Given this list of marker genes NDUFAB1, MRPL20, TPBG, DGCR6, CPEB1, FAM53A, CCER1, GUCA1A, LIF, RRM2, ATE1, DUSP2, MAOA, CDK2AP1, HES1, LAMTOR4, SNAPC2, EIF4G1, PGM1, SKP1, MTAP, AGTPBP1, BCL2L1, HCLS1, PRDX1, PIP, TMED7, CFL1, BRCC3, MRPL39 (mitochondrial ribosomal protein L39), MORN3, RWDD4, KRT2, FRK, FLNB, UBA1, ACTN1, TAC1, FOXD1 (forkhead box D1), CDK5, HSP90AA1, SAMSN1, HIVEP2 (HIVEP zinc finger 2), EIF6, NIBAN1, FKBP4, CSTF1, ZNG1B, GSR, ACAA1, SMARCE1, AREG, CMTM8, ORM1, PGRMC2, ZNRD2, RHBG, GUCD1, HOXA1, GRINA, OSTF1 (osteoclast stimulating factor 1), PTPN6, C14orf119, HJURP (NCBI Gene Id 55355), TMEM183A, ATP6V0B, MYCBP, DHPS, OTULIN, CLRN3, RLN1, TUT1, IER3, PMPCB, POFUT2, HCAR2, CCDC71L, KRT18, GTF2B, TTC39C, CYBB, CWC15, RAD17, PAM16, MTO1, SMARCA4, SRFBP1, DAPK1, TRMT10A, FABP7, P2RX3, JKAMP, TAF13, PSENEN (NCBI Gene Id 94939), NAMPT, CACYBP, RUSC2, KMT5A, SLC39A4, PWP2 (PWP2 small subunit processome component), ZMYND19, MRPL54, MKKS, SQSTM1, GSDME, LRRC59, VPS37C, TEX56P, IVD, PTPN11, COL11A2, ABCB4, P2RX1, HK2, EYA4, MGST2 (microsomal glutathione S-transferase 2), EIF2S2, N4BP1, GJA8, BCLAF1, MED28, SRRM4, PUM3, DLG5, TRAT1 (T cell receptor associated transmembrane adaptor 1), NCMAP, AOPEP, METTL6, SERPINB4, RRP12, GOLIM4, PDZK1IP1, BATF, GRWD1, IER3IP1 (NCBI Gene Id 55392), IGSF9, DDX39B, STYX, UGP2, PELI1, GPS1, UFSP2, MRAS, MAD2L1BP, SERPINI1, IAH1, KCNN4, PSMC4, CYFIP2, LARS1, GK, LARP4B, RBM8A, ZDHHC6, STARD5, CHRNB4, RBM47, GCLC, DDA1, LOXL4 (lysyl oxidase like 4, NCBI Gene Id 84171), UPP1, CHRAC1, YBX3, PDE4B, BST2, MRPL11, RNGTT, KRI1, ORMDL2, REPS1, IGF2BP1, ACKR2, SATB2, PADI1, SNRPD3, ERAS, POLR2H, MAFF, FAM98A, WIPI1, ITGB6, PLA2G7, PANX1, AQP7, USP15, NQO1, CACNG3, SAE1, CHCHD4, PPP1CB, PPIB, SLC31A1, SERPINA5, VTN, NIP7, MDN1, C1orf52 (NCBI Gene Id 148423), GBE1, ATP6V1E1, ADAMTS8, here is a description of the gene set: species: Homo sapiens Human Gene Set: GSE17721_CTRL_VS_PAM3CSK4_24H_BMDC_DN Genes down-regulated in comparison of control dendritic cells (DC) at 24 h versus those stimulated with Pam3Csk4 (TLR1/2 agonist) at 24 h. from publication Amit I, Garber M, Chevrier N, Leite AP, Donner Y, Eisenhaure T, Guttman M, Grenier JK, Li W, Zuk O, Schubert LA, Birditt B, Shay T, Goren A, Zhang X, Smith Z, Deering R, McDonald RC, Cabili M, Bernstein BE, Rinn JL, Meissner A, Root DE, Hacohen N, Regev A (PMID 19729616) mouse primary BMDCs were stimulated with tlr ligands and gene expression changes were profiled on Affymetrix arrays